Given this list of marker genes Anp32e, Slc6a8, Hnrnpu (heterogeneous nuclear ribonucleoprotein U), Hsp90b1, Cebpb, D17H6S56E-5, Cdo1, Maged1, Pdpn, Adam19, Ltbp2, Plpp3, Gtf2a2, Tmem176b, Ppid, Emb, Casp4, Ifi204, Eno2, Top1, Tpst1, Ncam1 (NCBI Gene Id 17967), Nav2, Slc16a1, Ccnb2, Lsp1, Atp13a3, Lama4, Efnb2, Phlda1, Phldb2, Ank3, Ifi205, Htatsf1, Mgp, Agtr2 (NCBI Gene Id 11609), Xdh, Tnc, Pla2r1, Nap1l1, Plscr1, Nid1, Lpar1, Crabp1, Csf1, Erdr1, Prxl2a, Cyp1b1, Fgf7, Myl12b, Ptx3, Ccl2, Pdk3, Twist1, Eif2ak4, Capn6, Igf2, Dpep1, Sephs2, Ivns1abp, 1810030O07Rik, Lxn, Hmgn2, Apbb1ip, Cask, Pdk4, Rab11a, Grem2, Srsf3, Taf1d, Arxes2, Ube2d2a, Loxl1, Cxcl5, Enah, Igsf10, Noct, Ifi202b, Cebpd (NCBI Gene Id 12609), Rbm3, Dlk1, Noc4l, Man2a1, Ramp3, Pfn2, Hmga2, Ngef, Srsf6, Smoc2, Has2 (NCBI Gene Id 210441), Fgfr2, Gpc4, Errfi1, Slc12a2, Thbs1, Ifi207, Synpo, Aox1, Ctsb, Pspc1, Il1rl1, Pcf11, Il6, Fam3c, Chi3l1, Vcam1, F2r, Osmr, Thy1, Bach1, Vcan, Slc38a2, Srrt, Tmem176a, Impact, Evl, Prl2c2, C3 (complement component 3), Utp14a, Saa3, Npnt, Lamp2, Il1r1, Pgrmc1, H2ax, Pten, Lmo7, Thbs2, here is a description of the gene set: species: Mus musculus from publication Chiaradonna F, Sacco E, Manzoni R, Giorgio M, Vanoni M, Alberghina L (PMID 16607279) Genes up-regulated in reverted NIH3T3 cells (fibroblasts transformed by activated KRAS which then reverted to normal cells upon stable over-expression of a dominant negative form of CDC25) vs normal fibroblasts. Mutational activation of ras genes is required for the onset and maintenance of different malignancies. Here we show, using a combination of molecular physiology, nutritional perturbations and transcriptional profiling, that full penetrance of phenotypes related to oncogenic Ras activation, including the shift of carbon metabolism towards fermentation and upregulation of key cell cycle regulators, is dependent upon glucose availability. These responses are induced by Ras activation, being specifically reverted by downregulation of the Ras pathway obtained through the expression of a dominant-negative Ras-specific guanine nucleotide exchange protein. Our data allow to link directly to ras activation the alteration in energy metabolism of cancer cells, their fragility towards glucose shortage and ensuing apoptotic death. Mouse Gene Set: CHIARADONNA_NEOPLASTIC_TRANSFORMATION_CDC25_UP